Given this list of marker genes Rftn1, Il21, Opa1, Prkcq, Nr1h4, Nod2, Phb1, Osm, Card9, Il18, Tyk2, Btk, Il12b, Slamf6, Il2, Tgfb1, Zbtb7b, Slc7a5 (solute carrier family 7 (cationic amino acid transporter, y+ system), member 5), Il6, Il23a, Il15, Ccl1, Ccn1, Arid5a, Myd88, Ly9, Sphk1, Jak2, here is a description of the gene set: species: Mus musculus Mouse Gene Set: GOBP_POSITIVE_REGULATION_OF_INTERLEUKIN_17_PRODUCTION Any process that activates or increases the frequency, rate, or extent of production of any member of the interleukin-17 family of cytokines.